The following is a description of a gene set: Human Gene Set: KEGG_MEDICUS_REFERENCE_BCR_PLCG_CALCINEURIN_SIGNALING_PATHWAY Pathway Definition from KEGG: IGH -> (LYN,SYK) -> (BTK,BLNK) -> PLCG2 -> IP3 -> Ca2+ -> CALM == CN -> NFAT BCR-PLCG-Calcineurin signaling pathway. Pathway ID: N00487. Pathway type: Reference. Pathway class: nt06220 Calcium signaling. studied in species Homo sapiens, and this is the list of marker genes: SYK, BTK, PPP3CB, CALM1, LYN, PLCG2, NFATC2, NFATC4, PPP3R2 (protein phosphatase 3 regulatory subunit B, beta), CALM3 (NCBI Gene Id 808), NFATC1, PPP3CA, ENSG00000275063, BLNK, PPP3R1, PPP3CC, NFATC3, CALM2